The following is a description of a gene set: An abnormal position of the hand in which the wrist is bent toward the radius (i.e., toward the thumb). Radial deviation of the hand Human Gene Set: HP_RADIAL_DEVIATION_OF_THE_HAND species: Homo sapiens, and this is the list of marker genes: COL9A2, RBM8A, ZC4H2, SALL4, EIF4A3, SAMD9, COL9A3, BGN, RECQL4, COL9A1, GLI3, TBX5